Given this list of marker genes CDKN1A, NPR1, HGSNAT (heparan-alpha-glucosaminide N-acetyltransferase), SAG, DENND4A, SMAD3, DUSP3, TIRAP, IER3, ADGRF5, FAM135A, RHOB, RORA, SLC66A2, RBPJ, TUB, SELENOM, CCR4, CLDN12, SNX9, ITGAV, S1PR2, GOT1, FOXL1, SEC16B, ELF1, PIM3, ITPRIPL2 (NCBI Gene Id 162073), ANXA6, PTPN4, NDRG4, NID2, IL18RAP, ZCCHC14, NOP53, CCDC184, MT2A, IL10RA, NR1D2 (nuclear receptor subfamily 1 group D member 2), DNAJB2, AQP12A, MIR22HG, ZC3H12A, NFKBIB, TSC22D2, PLD1 (phospholipase D1), ASAH1, HS6ST2, PRKCG, MIF4GD, MAFF, SLC41A2, GM2A, PLEC, HLF, S100A4, CEP170, TSHZ1, RHOC, ZNF503, CCNG1, PGAP6, MLF1, LCLAT1, ARSB, PLS3, BHLHE40, SP6, IFNGR1, STX11, VPS37B, GNAQ, PARD3, EPB41L4A (NCBI Gene Id 64097), GCH1, INPP5D, RUNX2, FEM1C, ELL2, SRPK3, KDSR, YPEL2, DIAPH1, TGIF2, ATF4, PHLDA1, BLTP3B, ABCB1, LINC00511, FLNB, SORBS1, HERPUD1, ENTREP1, DNAJB12, JMY, PLXDC1, GINM1, PLIN2, APOBEC3B, CCR2, CLEC4M, TMEM140, ACOD1 (aconitate decarboxylase 1), RAB11FIP5, COQ8A, MIDEAS, FAM114A1, ZNF703, SPACA1, ARL13B, DRAM1, KRT33A, ADRB2, SAMSN1, PCDH19, FAM177A1, SLC35E2B, ZDHHC2, KLRG1, MYO6, CKB, RGMB, FGF14, KLF16, ST14, TENT5A, INSIG1 (NCBI Gene Id 3638), NR2F1, CBX7, RAP1GAP2, ARRB1, WSCD2, NFKBIE, TYRP1, FZD4, CD200R1, APLP1, PHF19, MMP9, UBALD2, ABLIM3, CAPS2 (calcyphosine 2), ACTR1A, SHROOM4, PER1, FZD5, TNF, KIAA1191, JDP2, KCNJ14, TRIM36, CPNE8, MANSC1, TJP2, TIPARP, CYP4V2, CASS4, IMPACT, CD99, IL12RB1, NCKAP1, MAT2A, RAB43, APBB1, IL15RA, SLC38A2, CXCR6, TMEM273, SMIM3, IRF5, TNFSF9, ATF6 (activating transcription factor 6), CTNND1, CLTC, NDEL1, BMP2K, KIAA0930, ARL14EP, TPPP3, MFN2, PRKAB2, ENPP4, FADS6, MRS2, UNC5B, CIB4, VOPP1, SQSTM1, BRD2, PKD2, CRIP2, IER5L, ARHGAP23 (Rho GTPase activating protein 23), H3C7 (H3 clustered histone 7), ADCY7, TSPAN13, CCR3, YAF2, GLS2, RAB4A, here is a description of the gene set: Comparisons of global gene-expression profiles revealed a greater distinction between CD4+ Treg cells and CD4+ conventional (Tconv) T cells residing in abdominal (epidydimal) fat versus in more standard locations such as the spleen, thymus and LN. studied in species Homo sapiens Genes down-regulated in comparison of thymus regulatory T cells versus fat tissue regulatory T cells. Human Gene Set: GSE7852_THYMUS_VS_FAT_TREG_DN from publication Feuerer M, Herrero L, Cipolletta D, Naaz A, Wong J, Nayer A, Lee J, Goldfine AB, Benoist C, Shoelson S, Mathis D (PMID 19633656)